Given this list of marker genes KNL1 (NCBI Gene Id 57082), CHFR, TTK (TTK protein kinase), ZWINT, MOS, here is a description of the gene set: species: Homo sapiens Any process that stops, prevents or reduces the frequency, rate or extent of meiotic chromosome separation. Human Gene Set: GOBP_NEGATIVE_REGULATION_OF_MEIOTIC_CHROMOSOME_SEPARATION